Given this list of marker genes Ocm, Tspear, Pjvk, Ush1c, Myo7a, Adcy6, Cib2, Rhoc (NCBI Gene Id 99594), Pkhd1l1, Pafah1b1, Elmod3, Calb1, Piezo2, Tprn, Eps8l2, Tmc1, Espn, Espnl, Mpp1, Trpa1, Ceacam16, Rac1, Nherf1, Rsph9, Kptn, Triobp, Bbs2, Myo15a, Clic5, Zswim6, Prom1, Mkks, Cdh23, Piezo1, Nherf2, Ido1, Fscn2, Tiam1, Vezt, Pdzd7, Loxhd1, Ush2a, Ripor2, Kncn, Dcdc2a, Myo3a, Myo1c, Grxcr1, Strc, Pvalb, Grxcr2, Dock4, Adgrv1, Whrn, Myo3b, Minar2, Morn4, Ptprq, Calb2, Clrn2, Ankrd24, Ift20, Rdx, Ift88, Twf2, Mcoln3, Clrn1, Cdc14a, Pls3, Tmc2, Slc4a7, Lhfpl5, Stx4a, Homer2, Fchsd2, Eps8, Coro1a, Atp8b1, Pcdh15, Pls1, Diaph3, here is a description of the gene set: A bundle of cross-linked stereocilia, arranged around a kinocilium on the apical surface of a sensory hair cell (e.g. a neuromast, auditory or vestibular hair cell). Stereocilium bundles act as mechanosensory organelles by responding to fluid motion or fluid pressure changes. studied in species Mus musculus Mouse Gene Set: GOCC_STEREOCILIUM_BUNDLE